Given this list of marker genes AFF1, EPHA4, YME1L1, FMR1 (NCBI Gene Id 5421), EYA4, FKTN, ELL, FLRT3, TRIL, ZNRF3, PSMD5, RGS17, ZNF606, RAB3C, DLG3, CACNA1D (NCBI Gene Id 776), CDHR1, OSBPL11, ZNF445, CAMLG, DSE, BTBD3, PMAIP1, TMED5, FRAS1, PTPN12, ATAD2B, GPD2, PTBP2, ZNF521, ZFR, MATCAP1, GPR137B, LAMA1, GAL3ST3, RPS6KB1, ASTN2 (NCBI Gene Id 23245), SUMO3, PLAAT5, PDLIM5, LRRN1, EDN1, ANKLE1, SEPTIN8, STX7, IKZF2, C6orf62, ATM, SRSF7, ZNF367, ERCC8, HSP90AA1, CUL5, MME, KRIT1, ARMCX4, here is a description of the gene set: from publication Chen Y, Wang X (PMID 31504780) Genes predicted to be targets of miRBase v22 microRNA hsa-miR-6502-3p in miRDB v6.0 with MirTarget v4 prediction scores > 80 (high confidence targets). Human Gene Set: MIR6502_3P studied in species Homo sapiens